Given this list of marker genes PFN2, CCDC73, RORA, ARL5A, BCL2L2-PABPN1, PRKG2, MYSM1, MYLIP, SLC30A5, MAGEA12, ERLIN2, SESN1, HERC3, MAGEA2, COPS7B, ERCC6L2, MFAP1, FXYD6, ANXA11, SAMD12 (sterile alpha motif domain containing 12), PLIN1, GALC, VOPP1, PRICKLE2, TANC2, TRANK1, CAPN7, BMAL1, NHEJ1, SASH1, HDAC9, APOBEC3B, NAV3, PEDS1-UBE2V1, HTR4, ARK2N, NECAB1, CD40LG, ALG6, ADAMTS5, ZIC3, EDIL3, SHISA9 (shisa family member 9), KDM3B, ADAR, NSD2, ARL4C, FTH1, VGLL3, ZDHHC17, CAST, GFM1, POU4F1, RIMKLB, PDCL, INTS7, MAGEA6, CEP170, DMKN, MGMT, ADSS2, NFIB, BARD1, ARAP2, SLC18A2, FZD5, INSYN2A, ACKR3, MAGEH1, CNGB1, NFATC3, ADGRD1, FMNL2, TBC1D12, MAGI2 (NCBI Gene Id 9863), VCPIP1, GFRA1, MTA3, OCLN, EVI2B, FBXL20 (NCBI Gene Id 90110), ARB2A, DCP1A, THRB, NOVA2, VTCN1, HDLBP, FBXO34, NUP58, CACNB4, MAGEA3, WDR20, EIF1B, NREP, TATDN3 (NCBI Gene Id 128387), KLHL24, SCN2B, AMD1, EDNRA, TCF20, TXNDC15, PLCB4, PTAR1, SLC38A1, RAB33A (RAB33A, member RAS oncogene family), ALDH1B1, TBC1D2B, LAMC1, DZIP1, RNF4, SMYD1, GOSR1 (golgi SNAP receptor complex member 1), CRACDL, ZNF706, TXNL1, PHF13, SHPRH, CACYBP, APBB2, SEMA3A, PGBD5, KAT2B (NCBI Gene Id 8850), KANSL1, AFF3, GPR15, PCDH11X, FBXO22, NFIA, CUL4A, TMEM50B, MAGEA2B, NRP1, ANGPT1, MOB3B, INO80D, OTUD4, PPP2R1B, TAF7, SNTN (NCBI Gene Id 651293), KSR2, ARF1, ZBTB18, FZD6, RBM18, SALL4, STX3, LZTFL1, TOM1L2, CNOT6L, TBC1D32, CWC15, LMO1, CMKLR2, LTBP2, CS, RBMS3, ZNF697, HMGA2, ZC3H8, PMM2, UTRN, ADNP2, SYK, SETD9, PPARA, GRIA3, A1CF, PCDH11Y, BCL11A, FCGR2B, GRID2, PHF8, CNRIP1, SEC11A, SRFBP1, TNKS, NAV1, IKZF1, MESD, MFAP3L, FBXL3, TRDMT1 (NCBI Gene Id 1787), PCSK1, HSPE1, DGKI, RBM22, ZNF789, ZNF160, SERPIND1, CHD9, MAP3K1, PABPN1, PEAK1, AGO3, ZNF148, TBL1XR1, ACAN, TWIST1, GMFB, XPO4, KCNIP1, RIOK3, WAC, RAD51, USP15, MYEF2, WASHC4, MAP1B, LAIR1, PCDH7 (protocadherin 7), EEIG2, PTPRM, C2orf69, FGG, PPFIBP1, DIAPH1, TRIM67, IL26 (interleukin 26), WDR31, SHQ1, ONECUT2, ILRUN (NCBI Gene Id 79138), PPP1R3B, PARP9, KDM5A, CADPS2, SLF2, AGO1, TMX4, CLASP2, PDE1C, PABIR2, SH3PXD2A, DUSP16, KMO, XPNPEP3, ZIK1, ANAPC1, CX3CR1, ARPIN, MTO1, TMTC3, NEGR1, CLOCK (NCBI Gene Id 9575), CAMKK2, DLGAP1, DCBLD2 (NCBI Gene Id 131566), CHP1, HCN1, ELAPOR2, IL17RD, PNPLA4, MAP3K14 (NCBI Gene Id 9020), RNF38, MED13L, PDGFRA, HAND2, TIMELESS, NFATC2, HIPK2, SEZ6, OTUD1, LACTB, MRPL43, GTF3C4, TLCD4, VCF1, CRKL, DCAF7 (NCBI Gene Id 10238), MEF2C, CAP2 (NCBI Gene Id 10486), SYTL4, AGPAT5, FNBP1L, ABCD2, SERP1, PLCXD3, MCC, HASPIN, STX18, AAK1, GOLPH3L, TREML2 (NCBI Gene Id 79865), DOLPP1, DDHD1, SCN2A, MLLT6, RANBP9, PAFAH1B1, AKIRIN1, USP37, SPRED1, BRAP, MEIOC, LYN, CALHM5, TET1, SRR, FBXL5, AKAP10, AHR, BRSK2, GRIK2, PRRC2B, RABL2A, DKK2 (dickkopf WNT signaling pathway inhibitor 2), MROH2A, PLEKHA8, ADCY6, ZBTB34, SRSF4, BUB3, PLPPR5, ATP6V0D2, COL4A6, TENM3, RPP14, KCNK6, ZBTB20, SP3, PCLO, DLD, BLTP3A, NFYC, ZMYND11 (NCBI Gene Id 10771), LRRTM4 (leucine rich repeat transmembrane neuronal 4), DIPK2B, PHIP, ATXN7, ADARB1, FAM13A, CRCP, EMC4, MYO19, MBD2, NAV2 (NCBI Gene Id 89797), GNG4, FGF13, SERPINB5, RNF8, USP45, ARF3, PCDH18, FAF2, SYBU, DPF3, FMN1, HS2ST1, RASSF3, TMEM59, TNFSF15, GRIA2, MID2, NCAM1 (neural cell adhesion molecule 1), SLTM, MAB21L1, SUSD6, ADAM28, CHD6, CREB3L2, LSAMP, TRIM42, TLE1, ASTN2, FUT9, PIAS2, PHYHIPL, UBE2V1, SH3GLB1, ARID4B (NCBI Gene Id 88087), RNPC3, CASD1, ZC3H12C, CPQ, PCDH19, PCYT1B, CNIH1, PRXL2A, SEC13, SLC35E2A, RGS5 (regulator of G protein signaling 5), EML4, SSX7, MLEC, NAA20, STAU2, NEMP1 (nuclear envelope integral membrane protein 1), EBAG9, CDKN2AIP, ABRA, PDE4D, PTPRK, PFKFB2, OPHN1, FAM120A, ZNF407, RHOBTB1, SKA1, NCK1, AAR2, KRTAP1-5, NPTN, FOXO1, TCF7L2, SUGP2, CELSR3, SPCS1, LARP4, GABRA1, C1S, APOOL, ZBBX, GOPC, TRAF3IP2, CD164 (CD164 molecule), EMP2, NEUROD1, UBE2W, XPR1, AGAP2, PGM3, SOX13, LIN7A, TIGD3, QSER1, RAB2A, PROX2, INAFM2, SVEP1, NAA15, PARPBP (NCBI Gene Id 55010), MEX3C, MX2, CHRNB2, ZNF704, PLXNA4, C9, BNC2, VPS4B, DPPA4, RRP15, G3BP2, here is a description of the gene set: from publication Chen Y, Wang X (PMID 31504780) species: Homo sapiens Genes predicted to be targets of miRBase v22 microRNA hsa-miR-4261 in miRDB v6.0 with MirTarget v4 prediction scores > 80 (high confidence targets). Human Gene Set: MIR4261